The following is a description of a gene set: species: Mus musculus The series of molecular signals in which an intracellular signal is conveyed to trigger the apoptotic death of a cell. The pathway is induced by the cell cycle regulator phosphoprotein p53, or an equivalent protein, and ends when the execution phase of apoptosis is triggered. Mouse Gene Set: GOBP_INTRINSIC_APOPTOTIC_SIGNALING_PATHWAY_BY_P53_CLASS_MEDIATOR, and this is the list of marker genes: Bmyc, Trp53bp2, Cd44, Phlda3, Ifi206, Tifab, Perp, Casp6, Msx1, Ptprv, Topors, Ifi208, Ddit4, Wwox, Ddx5, Ifi207, Kdm1a (lysine (K)-specific demethylase 1A), Jmy, Pou4f2, Rps27l, Shisa5, Sh3glb1, Ercc2, Hipk1, Ell3, Pycard, Mdm4, Ubb, Trp73, Bok, Ifi203, Myc, Ifi203-ps, Uri1, Ppp2r5c, Eda2r, Hipk2, Pou4f1, Bcl2l12 (NCBI Gene Id 75736), Bcl3, Ifi214, Bbc3, Bag6, Mndal, Pml, Atad5, Steap3, Ifi209, Usp28, Hnrnpk, Bdkrb2, Snw1, Rrm2b, Mif, Zfp385b, Trp53, Hint1, Usp15, Ppp1r13b, Sirt1, Dyrk2, Knl1, Rps7, Fhit, Rrp8, E2f2, Muc1, Rpl26, Marchf7, Rrn3, Ep300, Trp63, Bax, Cdip1, Aen, E2f1, Pttg1ip, Ankrd2, Mdm2, Brca2, Nupr1, Pmaip1, Cdkn1a, Ifi204, Msh2, Cd74, Stk11, Armc10, Tmem109 (NCBI Gene Id 98142), Triap1, Chek2, Ifi213, Cep63, Prkn, Zfp385a, Mybbp1a, Pdk2